Given this list of marker genes PHF20, PPP1R13B (protein phosphatase 1 regulatory subunit 13B), PPP1R13L, POU4F1, AKT1, ZNF385A, TP73, POU4F2, AKT3, AKT2, TP53, TP53BP2, TP63, BANP (NCBI Gene Id 54971), here is a description of the gene set: Reactome Pathway: Regulation of TP53 Activity through Association with Co-factors studied in species Homo sapiens part of: Regulation of TP53 Activity Association of TP53 (p53) with various transcriptional co-factors can promote, inhibit or provide specificity towards either transcription of cell cycle arrest genes or transcription of cell death genes. Binding of the zinc finger protein ZNF385A (HZF), which is a transcriptional target of TP53, stimulates transcription of cell cycle arrest genes, such as CDKN1A. Binding of POU4F1 (BRN3A) to TP53 also stimulates transcription of cell cycle arrest genes while inhibiting transcription of pro-apoptotic genes.<p>Binding of ASPP family proteins PPP1R13B (ASPP1) or TP53BP2 (ASPP2) to TP53 stimulates transcription of pro-apoptotic TP53 targets. Binding of the ASPP family member PPP1R13L (iASSP) inhibits TP53-mediated activation of pro-apoptotic genes probably by interfering with binding of stimulatory ASPPs to TP53. Transcription of pro-apoptotic genes is also stimulated by binding of TP53 to POU4F2 (BRN3B) or to hCAS/CSE1L.<p>Binding of co-factors to TP53 can also affect protein stability. For example, PHF20 binds to TP53 dimethylated on lysine residues K370 and K382 by unidentified protein lysine methyltransferase(s) and interferes with MDM2 binding, resulting in prolonged TP53 half-life. Long noncoding RNAs can contribute to p53-dependent transcriptional responses. For a general review on this topic, see Espinosa 2008, Beckerman and Prives 2010, Murray-Zmijewski et al. 2008, An et al. 2004 and Barsotti and Prives 2010.